Given this list of marker genes Fgb, F11, Serping1, Vtn, Cpb2, Plg, Pros1, F12, F2, Fgg, Plau, Tmprss6, Anxa2, Serpine1 (serine (or cysteine) peptidase inhibitor, clade E, member 1), Gp1ba (NCBI Gene Id 14723), Hrg, Plat, Fga, Apoh, Klkb1, Serpinf2, Thbs1, Plaur, here is a description of the gene set: species: Mus musculus A process that solubilizes fibrin in the bloodstream of a multicellular organism, chiefly by the proteolytic action of plasmin. Mouse Gene Set: GOBP_FIBRINOLYSIS